Given this list of marker genes GPSM2, EPB41, GNAI1, NUMA1, EPB41L2, PPP1R9B, here is a description of the gene set: Human Gene Set: GOBP_POSITIVE_REGULATION_OF_PROTEIN_LOCALIZATION_TO_CELL_CORTEX Any process that activates or increases the frequency, rate or extent of protein localization to cell cortex. studied in species Homo sapiens